The following is a description of a gene set: studied in species Mus musculus Mouse Gene Set: GOBP_POSITIVE_REGULATION_OF_TRIGLYCERIDE_CATABOLIC_PROCESS Any process that increases the frequency, rate, or extent of the chemical reactions and pathways resulting in the breakdown of triglyceride., and this is the list of marker genes: Abhd5, Apoa4, Pnpla2 (patatin-like phospholipase domain containing 2), Fgf21, Apoa5, Apoh, Daglb, Ldlr, Apoc2l, Apoc2, Aadac